The following is a description of a gene set: Fluoropyrimidine activity Human Gene Set: WP_FLUOROPYRIMIDINE_ACTIVITY studied in species Homo sapiens, and this is the list of marker genes: ERCC2, UMPS, ABCC4, ABCC3, CES1, SLC22A7, ABCG2, TK1, PPAT, MIR29C, XRCC3, SMUG1, FPGS, UPP2, TYMP, DHFR (NCBI Gene Id 203373), RRM1, UPB1, ABCC5, DPYS (NCBI Gene Id 1807), DPYD, CES2, TYMS, CDA, RRM2, MTHFR, UCK2, GGH, UCK1, UPP1, SLC29A1, TDG, TP53, CYP2A6 (cytochrome P450 family 2 subfamily A member 6)